Given this list of marker genes CAPNS1, NT5DC4, EMP3, RNASE1, CRNDE, EIF1AY, CYTOR, EPB42 (erythrocyte membrane protein band 4.2), TP53I3, NAA50, PRDX5, ADIPOR1, RPL36AL, VCF1, PKLR, APRT, CAT, UROD, GMPR, NPRL3, BPGM, UBB, H2BC9, YBX1, GLIPR2, HINT2, GYPE, LXN, CPED1, NR1H2, RPS12, GATA1, SLC25A37, HBG2, RPL29, OPTN, BIRC2, TGM2, ERMAP, MT1E, CTSE, STRADB, GHITM, UBE2C, COX7B, NBAS, DCXR, SLC4A1, UBAC1, ALAD, NFE2, KLF1, SNX3, MYL6, TUBG1 (tubulin gamma 1), GFI1B, GNG11, SLC22A4, ADD3, EDNRA, PMEL, RPL35, RGS10, BGN, ATP5F1E, NDUFB6, ST6GALNAC1, KLF3, WASF2, TALDO1, TSPAN32, CENPF, ANK1, HBZ, NCOA4, FAM210B, CKS2, IQGAP2, MTURN, TRAK2, PLXND1, CD36, XK, COX6B1, YBX3, TESC, RRM2, ELOF1, BTF3, FURIN, HBA2, TMA7, BCL2L1, UBA52, GALNT10, SMIM5, HBE1, BUB1, SYNGR2, EMCN, CREG1, TNS1, PCOLCE, FIS1, MT2A (NCBI Gene Id 4502), AURKB, GSTP1, TMEM14C, CYP26A1, DHFR, KEL, TENT5C, ADA, NPL, SPTB, GSTK1, SEC62, MYH9, SELENBP1, PIM2, TMOD1, GSTO1, OSBP2, CENPH, GUK1, PPOX, ITM2A, BIRC5, EPOR, AURKA, C17orf99, MYL4, SNCA, RPA3, TXNIP, SHLD1, MT-TL1, PTTG1, YOD1, RHOG, ARID3A, CTSC, CTSL (cathepsin L), TRIM56 (NCBI Gene Id 81844), TMEM14B (transmembrane protein 14B), TYMS, S100A4, CENPW, USP15, FTL, HK1 (NCBI Gene Id 59333), ZMAT2, CDKN3, GYPB, UROS, HBB, RBX1 (NCBI Gene Id 9978), GYPC, COL3A1, WDR26, MPP1, NID1, HLA-E, EMX2, HMBS, TFRC, SLC1A5, RPS2, OAZ1, TUBB6, MRC2, TTLL12, MPC2, PITX1, EIF2AK1, ARL4A, COL1A2, MIR4458HG, ALAS2, SMIM1, RHAG (NCBI Gene Id 6005), LMO2, TLCD4, PRDX6, CCND3, MT1X, NDC80, CR1L, HCN3, GYPA, ESPN, UCP2 (NCBI Gene Id 7351), MKI67, ELOB, PPP1R15A, HEMGN, ANLN, CXCL12, EIF1, TROAP, DCT, TAL1, CDC42EP1, SLC39A8, SLC2A1, CHPT1, HBM, MIR4435-2HG, APOBEC3C, FAXDC2, MELK, COL1A1, HSF1, SNX22, RAP1GAP, ANXA2R, PCGF5, NUF2, EIF3K, CPOX, ATP5MF, SPTA1, DCAF12, PSMF1, FBN2, PODXL, CCNDBP1, PIM1, PRXL2A, GLRX5, STOM, B2M, MIR99AHG, GALNT2, CIT, TUBB1, SERF2, MT1H, ABCB10, NUDT4, TMT1A, RBM38, ELF1, UFD1, UXT, FECH, CALM3, HBZP1, FAH (NCBI Gene Id 2184), SPECC1, MGST1, PCBD2, MT1F (metallothionein 1F), RIPOR3, HBG1, HBA1, HPS1, ANXA1, HHEX, POLR2L, LGALS1, PDCD10, MT1G, RHCE, TCF19, FTH1, AHSP, EDN3 (endothelin 3), SNORD3A, ANP32B, ELL2, FTLP2, CTSB, DMTN, BLVRB, S100A6, FBXO7, SLC25A39, TMEM141, HBQ1, RGCC, PRDX2, here is a description of the gene set: species: Homo sapiens Human Gene Set: HU_FETAL_RETINA_BLOOD from publication Hu Y, Wang X, Hu B, Mao Y, Chen Y, Yan L, Yong J, Dong J, Wei Y, Wang W, Wen L, Qiao J, Tang F (PMID 31269016) Fetal Blood Cells